Given this list of marker genes LIG4, KPNA1, XRCC6, BANF1, PPIA, XRCC4, FEN1, XRCC5, CXCR4, HMGA1, CD4, CCR5, PSIP1 (PC4 and SRSF1 interacting protein 1), LIG1, here is a description of the gene set: Human Gene Set: REACTOME_EARLY_PHASE_OF_HIV_LIFE_CYCLE Early Phase of HIV Life Cycle studied in species Homo sapiens